Given this list of marker genes ETNK1, LPCAT3, SLC44A5, LPCAT4, PLA1A, PLA2G4B, PLAAT4, LPCAT2, BCHE, MFSD2A, PLA2G4C, AWAT2, OSBPL8, DDHD1, OSBPL10, PNPLA3, STARD10, PLA2G1B, AGK, CSNK2A2, PITPNM2, GPCPD1, STARD7, ALPI, GNPAT, CPNE6, LIPH, PLD1, PLD3, PTDSS2, LPGAT1, LPIN2, DGAT2, ACP6, AGPAT1, ABHD3, PCYT2, LPIN1, MBOAT7 (NCBI Gene Id 79143), TMEM86B, MIGA2, CHPT1, PLAAT3, CRLS1, PLAAT1, LPIN3, LIPI, AGPAT4, PNPLA2, PLA2G2A, PLAAT2, CHAT, CDS2, PGS1, SLC44A4, PLA2G2E, PITPNM3, AGPAT2, CHKA, GPAT2, PCYT1B, PLA2G6, CSNK2A1, PLA2R1, MBOAT1, PLA2G12A, ABHD4, CPNE7, TAFAZZIN, MIGA1, PTPMT1, PLA2G4E, GPAT4, OSBPL5, CSNK2B, PLA2G2D, GPAT3, CDIPT, PTDSS1, PLA2G4D, PLD6, CDS1, ETNK2, PITPNB, ETNPPL, PLA2G4F, DDHD2, SELENOI, PLD2, AGPAT5, GPD1, MBOAT2, CEPT1, PLA2G2F (NCBI Gene Id 64600), PEMT, DGAT1, PISD (phosphatidylserine decarboxylase), PLA2G10, ACHE, LCLAT1, PNPLA8, PLA2G5, PLAAT5, SLC44A2, CPNE3, PLA2G15 (phospholipase A2 group XV), PLA2G3, GPD1L, CHKB, DGAT2L6, SLC44A1, AGPAT3, PLD4, PHOSPHO1, CPNE1, PITPNM1 (phosphatidylinositol transfer protein membrane associated 1), MGLL, PLB1, PCTP, GPAM, LPCAT1, HADHA, PLA2G4A, PGP, SLC44A3 (NCBI Gene Id 126969), PLBD1, HADHB, GPD2, PCYT1A, here is a description of the gene set: Glycerophospholipid biosynthesis species: Homo sapiens Human Gene Set: REACTOME_GLYCEROPHOSPHOLIPID_BIOSYNTHESIS